Given this list of marker genes ZNF831, TRDN, PPARGC1A, CPEB3, NEDD1, HLA-DPB1, PIAS1, HORMAD2, FREM2, STOX2 (storkhead box 2), FN1, TNRC6B (trinucleotide repeat containing adaptor 6B), TBC1D26, SLC4A8, SLC18A2, THUMPD1, THBS3, COL27A1, SPAST, NRG3, BLTP3A (bridge-like lipid transfer protein family member 3A), ELK4, RBM41, RBM33, SMARCC2, U2SURP, TRIM44, GJA5, ANXA1, TRA2A, KCNB1, TCEANC2, UNC45B, RAB8A, BIRC6, VGLL3, ATP6V1A, ZNF322, HOXA9, GID8, MACC1, AP3M2, EXOC6B, IARS2, CXXC4 (CXXC finger protein 4), GAB3, MAPK9 (NCBI Gene Id 5601), N4BP1, ATRX, GOPC, HOXB7, ACSM2B, ZNF180, XPC, TANC2, ERBB4 (erb-b2 receptor tyrosine kinase 4), CACNA1D, TDRD15, ZNF510, PEAK1, INO80D, NUDCD1, CHIC1, OR2A4, CREM, CCPG1, TYW5, MOCS2, FBXO45, CHMP5, RFESD, JADE1, NIF3L1, CCNJ, FBXL20, SRA1, AP1G1, NTNG1, MSI2, IQGAP1, KDM2A, KPNB1, TNFAIP3, NMUR1, POU3F2, CLDN18, SASS6, GDAP2, WDR26, AAK1, UACA, TMEM220, ERICH3, FIGN, DNAJB12, RUFY1, FLT1 (fms related receptor tyrosine kinase 1), ZNF609 (zinc finger protein 609), LATS1, STXBP5, AMOT, SORL1, TPRG1, TNPO1, SUZ12, SEMA6D, ATP8A1, ZNF189, POLR1A, RND2, PDPN (podoplanin), RIDA, MESD, PIP5K1A (NCBI Gene Id 8394), TMEM52B, HIBADH, AFAP1L1, VCPIP1, LSAMP, CLDN1, MBD2, SYNPO2, TSPAN13, MARCHF6, RBM11, ST18, LRRK2, ZNRF2, LGI2, KLHL18, PURA, ZFP30, ST8SIA3, AMER2, TENM1, ATP8A2, NAA30, CEPT1, HEPACAM2, NCR3LG1, POGLUT3, CCNYL1, C6orf62, SH3BGRL2, RANBP10, LSM11 (LSM11, U7 small nuclear RNA associated), ANKDD1B, DDX6, GNG12, PLCB1, FGD6, WDR76, FRRS1, KBTBD8, MAGI3, ORC2, WDR37, WNK1, TSC1, AGO4, DMRTA1, COCH, ASXL2, FNBP1L (NCBI Gene Id 54874), NAA15, ACSM2A, MEOX2, PAK3, NUBPL, PERP, KIAA0825, CNOT4 (NCBI Gene Id 4850), SP4, TCF20, EPHA4, TMEM95, ZMIZ1, PCYT1A, OPRM1, TNFSF8, BAZ1A, CRIPTO, FBXO33, TRABD2B, LASP1 (LIM and SH3 protein 1), E2F5, SLC44A1, UNC13A (unc-13 homolog A), NHLRC2, ZNF618, TPST1, CALU, CISD1, C1orf21, TFDP2, CDH19, HERPUD1, CPEB2, ARFGEF3, PLEKHA8, VWA8, CLEC1A, SLC41A2, GIT2, KLHDC7A, PDZRN4, PGR, RTN4RL1, CEP97, ADAM22, IFT88, RAB39B, ZNF527, SLAIN2, MYO6, HIC2, PTPRO, MCFD2, ZNF268, here is a description of the gene set: studied in species Homo sapiens Genes predicted to be targets of miRBase v22 microRNA hsa-miR-3124-3p in miRDB v6.0 with MirTarget v4 prediction scores > 80 (high confidence targets). from publication Chen Y, Wang X (PMID 31504780) Human Gene Set: MIR3124_3P